The following is a description of a gene set: Human Gene Set: HP_FIBULAR_APLASIA species: Homo sapiens Fibular aplasia Absence of the fibula., and this is the list of marker genes: WNT7A, GDF5, RBM8A, BMPR1B, TBX15, LMBR1, AMER1, FLNB, FLNA, CPLANE1